The following is a description of a gene set: Human Gene Set: GOMF_L_ASPARTATE_TRANSMEMBRANE_TRANSPORTER_ACTIVITY Enables the transfer of L-aspartate from one side of a membrane to the other. L-aspartate is the anion derived from aspartic acid. species: Homo sapiens, and this is the list of marker genes: SLC25A18, SLC1A6, SLC1A4, UCP2, SLC1A1, SLC25A12, SLC1A5, SLC25A22, SLC25A13